The following is a description of a gene set: Juvenile onset studied in species Homo sapiens Human Gene Set: HP_JUVENILE_ONSET Onset of signs or symptoms of disease between the age of 5 and 15 years., and this is the list of marker genes: FTH1, CYBA, ATP1A3, NCF1, ADNP, GNRH1, MYO1E, KCNT1, PSENEN, SPG7, SYNE2, SMAD9, KCNQ1, CD4 (NCBI Gene Id 920), ARL6, VAMP1, SOCS1, GBA2, FOCAD, FYB1, IDH3A, TIE1, ZSWIM7, MYPN, MAFB, AARS2, GLA, FDX2, MPZL2, LIPA, HAVCR2, KMT2D, TNPO3, SCARB2, FOXL1, CHRNA1, GNPTAB, KCNA1, ELF4, WARS2, LITAF, IRF3, MRE11, RYR2, CCDC39, DNAH9, COL2A1, TRAF3IP2, SCNN1B, SLC5A7, GNPTG, NUP133, UMOD, TUBB4A, DNM1L, CASK, PPP2CA, KCND3, ALDH5A1, SLC17A9, BTK, GCK, SPRY4, C1QBP, CAV3, SGCE, ARHGEF1, ADRA2A, ATP6V0C, ACTN2, EXTL3, TINF2, NDUFS3, PMP22, PROC, RCBTB1, CDH2, LAMB2, STT3A, RRAGD, CBS, SLC2A1, ANO5, CTNNA3, COL7A1, PIK3R1, CSTB, TRPV4, GTPBP3, CFAP410, ALPK1, NUP160, FGF17, CLCN2, REST, CFH, COL4A3, AGBL5, SH3BP2, TERT, ATP1A2, MPV17, PLAAT3, SH3TC2, CLDN19, PPP1R13L, SGCG, MYH9, RIGI, SLC5A6, AAAS, SLC2A10, TBX18 (NCBI Gene Id 9096), ZNF408, HPS5, SLC37A4, PTF1A, ABCA4, EGR2, FN1, MGME1, TLR3, ATP2B3, CBFB, DOK7, DAB1, HYAL1, TGFB1, MAPKBP1, WDR11, KISS1, SIGMAR1, LDHA, CACNB4, PRDX1, KDM6A, GFAP (NCBI Gene Id 2670), PLA2G6, EIF2AK2, PDK3, CAP2, MBD4, PANK2, RAF1, IFNAR1, DHDDS, DCLRE1B, PDGFRB, WRN, MIEF2, SLC12A3, DGKE, GLB1, IBA57 (NCBI Gene Id 200205), RP2, STX1B, FXN, AIRE, CPA6, GNAS, SPTAN1, LMNA, TANGO2, VPS16, DOCK11, ANK1 (NCBI Gene Id 286), PKD2, CACNA1C, DUT, RTN2, HPCA, RETREG1, SLC12A5, CFI, ZMYND10, DMD, TNNT2, FKTN, PRKAR1A, KIRREL1, APRT, THAP1, PRKAG2, POMGNT2, SCO2, BBS1, G6PD, FOXC1, REEP6 (NCBI Gene Id 92840), REEP2, COQ8B, ANLN, MEFV, TSPOAP1, FGFR3, ACTC1, CNTNAP2, SCNN1G, DIABLO, SPG11, ASAH1, MCM3AP, SCN5A (sodium voltage-gated channel alpha subunit 5), KCNN2, CHRNA2, BFSP1, TTC19, SLC16A12, ITK, GANAB, SEC61A1, TYMS, TDP1, PTPRQ, NCF2, SLC19A3, KPTN, MPZ, ADSS1, DNAJC30, CTNNA1, SLC19A2, GAN, SMN2, NEK8, MAF (MAF bZIP transcription factor), SLC6A1, CDSN, RORB, NEXN, TWNK, SLC34A2, TPM2, LAMP2, RNH1, SLC52A3, GK, CYP11B1, ATP6V0A1, NUP107, MMP13, CLN3, ERLIN2 (NCBI Gene Id 140906), MTRFR, LMX1B, STAT3, PRDM16, MICAL1, VWA8, PDE11A, MECR, TRDN, CLN8, RPA1, BSCL2, TCF4, GALNS, STIM1, EIF2AK4, SLC26A3, PIK3CG, RYR3, DKC1, FOXD3, DAAM2, MCM6, MYL3, HPRT1, PI4KA, DHTKD1, ALG6, IMPG2, UBAP2L, CRYGS, FA2H, WFS1 (wolframin ER transmembrane glycoprotein), CYP2U1, ERLIN1, P4HA2, PRRT2, PRPF8, TNFRSF9, NEFL, PHKG2, FTL, AOPEP, SMN1, HK1, PYROXD1, HNRNPA2B1, SGCA, CILK1, COQ4, NAGLU, USP48, OTC, ANKH, RHBDF2 (rhomboid 5 homolog 2), PRICKLE1, CLDN9, EIF2B1, MYZAP, MARS2, DZIP1L, TPM3, MYH14, TBK1, NFKB1 (NCBI Gene Id 4790), INF2, LRIG2, CEBPE, LMBRD1, KCTD17, CAPRIN1, TNNC1, DNASE1L3, MCAT, WARS1, LPIN1, ATL3, ATP13A2, SLC39A5, COX20, INSR, NT5C2, TBC1D8B, SPTLC1, SERPINB7, NHLRC1, DYSF (NCBI Gene Id 8291), TRAPPC2 (NCBI Gene Id 6399), CISD2, DIAPH3, BBS5, CACNA1H, MYBPC3, BAG5, CYP7B1, ORAI1 (NCBI Gene Id 84876), PRPF4, MMP2 (NCBI Gene Id 4313), DUSP6, MAFA, NPHP1, RAB28, LTBP2, TLR8, ANO10, NUP85, CLCN7 (chloride voltage-gated channel 7), GJC2, LAMA2, PPT1, GIMAP5, ATP8B1, PEX7 (NCBI Gene Id 5191), MOCOS, VHL, IRF2BPL, SGCB, PTPA, MORC2, TNC, ACO2, SLC6A2, RAB7A, CARD10, ESR1, BICD2, CBLIF (cobalamin binding intrinsic factor), ABHD12, FDXR, FLNC, TRPM3, RP1L1 (NCBI Gene Id 94137), NDUFAF6, THRB, GCDH, HSCB, MAP1B, DHFR, SLC7A6OS, CASQ2, TUB, SNORD118, SGPL1, ERCC4 (NCBI Gene Id 7509), UCHL1 (ubiquitin C-terminal hydrolase L1), AFG3L2, ITPR1, GALNT3, WDR19, CRB2, SLC4A1, SCN4A, SLC4A3, KCNK3, LIG3, C3, CLCNKB, HPDL, FIG4, TTBK2, PEX11B, UNC13D, DSC2, SNUPN, SFRP4, CSF1R, UBQLN2, HSPB8, ATP2B2, CNTN2, EXT2, ACP5, COL17A1, HPS3, TENM4, SLC13A3, POLR3A, TACO1, REEP1, NRIP1, PNPLA6, BAAT, CWC27, MTMR14, MVK, SAMD7 (sterile alpha motif domain containing 7), CD46, MCM9, SLC25A19, NHP2, PMP2, SCN9A, RELN, RIPOR2, ATP11A, TTPA, RYR1, PEX10, HCN4, RPGRIP1 (NCBI Gene Id 57096), SEMA3E, SLC16A1, PPA2, STN1, CARS2, CTNNB1, EXT1, TMEM126B, LAMC3, CAV1, ENPP1, PNKP, CLCN1, SSBP1, IL6ST, PLP1, KIF12, C19orf12, MANF, FLRT3, BIN1, MMACHC, PDE6H, IFT140, SCN1A, ADA2, TMC1, HGSNAT (heparan-alpha-glucosaminide N-acetyltransferase), PIK3CD, RPS10, CHM, SPIDR, POLR3B, EIF2B4, CYBB, CASR, GAL, SLCO2A1, BVES, FEZF1, KISS1R, TULP3, NLRP3, TUBA3D (tubulin alpha 3d), NRCAM, HMGCR, PDGFB, PRKRA, PMVK, NDUFS8, DIAPH1, SLC39A14, PET117, GFPT1, MFSD8, TNNI3, MYOZ2, PLCE1, SCNN1A (sodium channel epithelial 1 subunit alpha), HINT1, NT5C3A, IGHMBP2, BMP15, CALM2, PSMC3IP, LMNB2, HSD11B1, DPM3, PYGM, KIF1C, SCP2, MYH7, LYRM7, FHL1, ATP6AP2, GNB4, PRKN, NR2E3, GNRHR (NCBI Gene Id 2798), TGFBR1, KCNJ2 (NCBI Gene Id 3759), DNAJC6, PRDX3, TMEM199, PIDD1, MAGT1, JAG2, ATP7A, DDB1, EMD, VRK1, TNFRSF4, ZNFX1, GABRA3, MSH5, CALM1, UBAP1, CEACAM16, CCDC141, TYMP, AARS1, IL36RN, SOHLH1, HMGCS2, COQ7, FBXO7, POLG, GNAL, SGO1, CAPN1, AXL, FDPS, NKX6-2, FBXL4, ALDH18A1, NPC1, CHP1, DPYD, GPNMB, MCCC1, TNNT1, ADCY5, OXGR1 (oxoglutarate receptor 1), HMBS, CIC, ERCC6L2, SMPD1, DBR1, KCNMA1, PHKA2, ATN1, CACNA1A, SVIL, CTNS, PAX8, OFD1, PTPRO, FANCM, COLQ, CCDC28B, FSHR, HADHB, SRA1, XPA, SPTLC2, PAX9, MRPS22, CD55, SAMD9L, HTRA1, CD19, NDUFS2, CAPN3, PIK3R5, CLDN16, POLE, KLF1, RRM1, CIB1, KIZ, PGK1, UBA5, IDS, TLCD3B, HROB, CIDEC, PAPPA2, SBF1, COQ6, MYMK, SEC23B, CASP10, MLIP, BAG3, PLEKHG5, IFIH1, TGFB3 (NCBI Gene Id 7043), ASS1, CARD9, MCCC2, SNF8, C1QC, ARL3, MFN2, KIF1A, SETX, SDHD (succinate dehydrogenase complex subunit D), SCN4B, POMGNT1, USP53, SLC30A9, OTULIN, LRP12, ANKS6, CHST6, COL9A1, CCDC50, SLC19A1, OBSCN, NR0B1, MACF1, SHANK3, STAT1, NPHS2, DEF6, YEATS2, TRNT1, AKAP9, TMEM53, EFHC1, B2M, LGI1, NGF, TECRL, MYRF, HYDIN, DSP, LOX, PFKM, NHLH2, DSG2, TGFBR2, SBF2, CD28, ADAM10, DNM2, TOM1, PDXK (pyridoxal kinase), STK4, EPRS1 (glutamyl-prolyl-tRNA synthetase 1), PDCD10, FBN1, ISCU, RP1, MARCHF6, NUP54, PANK4, SLC25A15, SGCD, CLN5, ANO3, TOR1AIP1, KRT16, CNNM2, ATP7B, TLR7, TMEM151A, ATL1, KCNC1, COL6A3, DNAJC3, MCM2 (minichromosome maintenance complex component 2), ZNF513, ATP1A1, TGFBI, PPARG, PRKG2, KMT2B, DDHD1, RNF216, TNFAIP3, IKZF1, APTX, P2RX2, H6PD